Given this list of marker genes Tubgcp3, Bloc1s2 (NCBI Gene Id 73689), Tubgcp5, Brsk1, Fez1, Pde4b, Lyn, Nedd1, Brca2, B9d2, Ddx3x, Nme1, Ndrg1, Rad51d, Pak1, Ofd1, Racgap1, Cep57, Git1, Mark4 (NCBI Gene Id 97378), D1Pas1, Tubgcp6, Washc1, Cenpj, Cimap3, Cdk5rap2 (CDK5 regulatory subunit associated protein 2), Tubgcp2, Spatc1, Dixdc1 (DIX domain containing 1), Arhgef7, Cep57l1, Wipf3, Cep70, Tubgcp4, Ndn, Rab11fip5 (NCBI Gene Id 97286), here is a description of the gene set: studied in species Mus musculus Binding to the microtubule constituent protein gamma-tubulin. Mouse Gene Set: GOMF_GAMMA_TUBULIN_BINDING